The following is a description of a gene set: species: Mus musculus Mouse Gene Set: chr5A3, and this is the list of marker genes: Iqca1l, Gm8539, Gm9836, Psmc2, Gm15587, Tmub1, Gm32102, Gm25459, Gm16111, Gm3724, Gm10475, Fam185a, Gm25761, Atg9b, Cdhr17, Gbx1, Cdk5, Smarcd3, Gm19088, Gsap, Wdr86, Kcnh2, Gm15719, Rheb, Sema3c, 2310074N15Rik, Gm6673, Mir671, Gm9057, Gm22054, Pus7, Asic3, Rsbn1l, Speer4f1, Napepld, Gm6543, Magi2, Gm55896, Pmpcb, E130116L18Rik, Lrrc17, Gm19666, Gm24512, 1110060G06Rik, Gnat3, Phtf2, Gm23822, Gm18830 (NCBI Gene Id 100417793), 2700038G22Rik (NCBI Gene Id 67194), Gm15715, Gm10472, Gm18343, Armc10, Gm22333, 6030443J06Rik, Rpl31-ps5, 2900005J15Rik, Abcb8, Ccdc146, Gm3544, Srpk2, Klhl7, Nup42, 1700022A21Rik, Gm18038, Cd36, Gm6564, Agap3, Gm31752, Slc26a5, Kmt2e, Reln, Asb10, Dnaja1-ps, Ptpn12, Gm17889, Lhfpl3, Gm3527, Rpl17-ps5, 4930580E04Rik, Gm22490, Gm6745, Prkag2os1, Gm15421, Galnt11, 1500035N22Rik, Abcf2, Gm15589, Tomm7, Gm8991, Fastk, A630072M18Rik, Chpf2, Tmem60, Gm7047, 5031425E22Rik, Dnajc2, Hspe1-ps3, Nos3, Gm21009, Slc4a2, Fbxl13, Hgf, Galntl5, Gm5575, Gm10221, Fgl2, Crygn, Speer4f2, Nub1, 4921504A21Rik, Gm9534, Orc5, Gm25335, Prkag2, Gm8984, Gnai1, Hycc1, A930003O13Rik, Gm6560, AI506816, Rint1, Rpl31-ps21, Gm9523